Given this list of marker genes Fer, Wdr48, Csf2ra, Fyn, Prl3d1, Prl7b1, Il31ra, Il4, Usp1, Stat5a, Il12b, Il22ra2, Il5, Prl7a1, Il21, Arl2bp, Prl8a1, Hamp, Cdk5, Crlf2, F2r, Cxcl5, Ep300, Ggnbp2, Ptprc, Il7r, Cdk5r1, Calm1, Ifnar2, Nf2, Prl3a1, Thpo, C1qtnf4, Ifnb1, Tnfrsf18, Il23r, Egf, Dab1, Suz12, Prl4a1, Elp2, Socs1 (suppressor of cytokine signaling 1), Ptpn2, Socs3, Ctf2, Pigu, Igf1, Lck, Ifnl2, Prl8a9, Ifnar1, Neurod1, Prmt2, Prl3d3, Lep, Pkd2, Cish, Prl8a2, Inpp5f, Jak1, Prl3d2, Notch1, Hes1, Prl5a1, Lif, Il23a, Epo, Nrtn, Ccl5, Clcf1, Fgfr3, Ephb2, Socs2, Parp14, Osm, Irf1, Sac3d1, Leprot, Cenpj, Il10rb, Jak2, Il6st, Mgat5, Ctr9, Hsf1, Adipor1, Tnfrsf1a, Pparg, Tbx1, Clec12b, Cnot7, Hdac2, Pkd1, Hes5, Prl7a2, Dot1l, Prl2c5, Hgs, Naglu, Calm2, Il9, Prl2c1, Il24, Il6, Camk2a, Csf1r, Gbp7, Prl7c1, Akr1b1, Gh, Il18, Csf2rb, Hnf4a, Pias1, Socs5, Il13, Pibf1, Il10, Stat4, Ptprt, Il6ra, Prl7d1, Nlk, Prl6a1, Bcl3, Ptk2b, Fam3c, Crlf1, Mir301, Prl2c3 (prolactin family 2, subfamily c, member 3), Ptk6, Stat6, Il10ra, Ercc6, Prl2c2, Stra6, Il12a, Crlf3, Prlr, Tnfsf18, Prl8a6, Pias4, Parp9, Osbp, Csf2rb2, Gadd45a, Ager, Csf2, Il20, Il3, Rac1, Tyk2, Hmga2, Tgfb1, Cntf, Cyp1b1, Il2, Ptprd, Stat5b, Il15, Prl3c1 (prolactin family 3, subfamily c, member 1), Ifnl3, Snhg20, Ghr, Ifng, Ptger4, Prl, Mst1, Hpx, Ret, Stat1, Il22, Kit, Stat2, Erbb4, Calm3, Prl8a8, Cav1 (caveolin 1, caveolae protein), Prl2b1, Jak3, Cd40, Prl2a1, Tslp, Tnf, Il15ra, Stat3, Traf3ip1, Sh2b3, Ctf1, Prl3b1, Isl1, Pecam1, Agap2, here is a description of the gene set: Mouse Gene Set: GOBP_CELL_SURFACE_RECEPTOR_SIGNALING_PATHWAY_VIA_STAT studied in species Mus musculus An intracellular signal transduction process in which STAT proteins (Signal Transducers and Activators of Transcription) convey a signal to trigger a change in the activity or state of a cell. The STAT cascade begins with receptor activation followed by activation of STAT proteins by kinases. It proceeds through STA dimerization and subsequent nuclear translocation of STAT proteins, and ends with regulation of target gene expression by STAT proteins.